Given this list of marker genes Gabpa, Herpud2, Twnk, Slc35c1, Ncl, Bsdc1, Mpped1, Ube2g1, Plscr1, Sntg2, Fignl1, Pitpna (phosphatidylinositol transfer protein, alpha), Rnf38, Slc35a1, Snx24, Klk7, Rab8b, Etv1, Ermap, Fyco1, Magi1, Slc30a9, Bcan (NCBI Gene Id 269452), Opa3, Mrps24, Mcm4, Ubn2, Irs1, Srpk2, Homer1, here is a description of the gene set: Mouse Gene Set: MIR_344G_3P_MIR_7070_3P from publication Chen Y, Wang X (PMID 31504780) species: Mus musculus Genes predicted to be targets of miRBase v22 microRNA mmu_miR_344g_3p, mmu_miR_7070_3p in miRDB v6.0 with MirTarget v4 prediction scores > 80 (high confidence targets).